Given this list of marker genes SCN2A, SCN9A, SCN1A, SCN4B, SCN10A, SCN7A, SCN3B, SCN4A, SCN3A, SCN8A, SCN11A, SCN5A, SCN1B, SCN2B, here is a description of the gene set: studied in species Homo sapiens A sodium channel in a cell membrane whose opening is governed by the membrane potential. Human Gene Set: GOCC_VOLTAGE_GATED_SODIUM_CHANNEL_COMPLEX